Given this list of marker genes CSF1R, CCN3, AKIRIN1, AGER, MAPK3, CYP19A1, ECM1, NINJ1, GCSAM (germinal center associated signaling and motility), WASL, P2RX4, SLC8B1, MDK (midkine), PLCB1, STK10, CD99L2, THBS1, LRCH1, SPNS2, TNFRSF14, GCSAML, TNF, CORO1A, IL12A, TNFSF18, C1QBP, TNFSF14, CD200, TRPV4, TGFB1, MTUS1, GREM1, LGALS9, MED23, PADI2, P4HB, RIPOR2, CXCL10, S100A7, SELENOK, IL27RA, RHOA, CXCL13, PTK2, CCL20, DOCK8, WNT5A, RARRES2, BCR, ABL1, DEFB131A, DEFB124, DDT, PLA2G7, ITGB3, AIF1, DUSP1, JAM3, CD81, MSTN, CCR2, CALR, BMP5, MIR146A, OXSR1, CCR7, LGMN, MAPK1, CD9, CRKL, MIA3, PYCARD, PDGFD, SERPINE1, CD69, ITGA4, STK39, SLAMF1, APOD, ADAM17, MIF, GPR15LG, ADAM8, LYN, SLIT2, ASCL2, C3AR1, ADTRP, WNK1, CRK, MOSPD2, ANO6, CCR6, EMILIN1, CXCL12, CX3CL1, C5, MADCAM1, JAM2, MIR24-1, CCL4, CCL7, APP (amyloid beta precursor protein), P2RY12, CCR1, CCL2, ABL2, XCL1, CCL3 (NCBI Gene Id 6348), C5AR1, CREB3, CD47, RIPK3, SLAMF8, TMEM102, NBL1, HMGB1, LGALS3, KLRK1, CXCL17 (NCBI Gene Id 284340), CSF1, CNN2, RTN4, CX3CR1, KLRC4-KLRK1, MMP14, AKT1, GAS6, SPN, PTK2B, FPR2, FADD, IL34, ADAM10, CCL5, CCL1, SPI1, NEDD9, TREM2, MMP28, STAP1, CD200R1, MSN, MIR128-1, PTPRJ, S100A14, CCL21, CMKLR1, AIRE, MICOS10-NBL1, here is a description of the gene set: Human Gene Set: GOBP_REGULATION_OF_MONONUCLEAR_CELL_MIGRATION Any process that modulates the rate, frequency or extent of mononuclear cell migration. Mononuclear cell migration is the movement of a mononuclear cell within or between different tissues and organs of the body. studied in species Homo sapiens